Given this list of marker genes Inppl1, Pip4p1, Rab14, Mtmr12, Arf3, Bmx, Plekha8, Tpte, Pi4ka, Inpp4a, Pik3c3, Pik3r1, Inpp5k, Gde1, Pikfyve, Pik3cd, Mtmr4, Tnfaip8l1, Pik3c2g, Pik3r5, Plekha3, Inpp4b, Plekha6, Pi4k2b, Ptpn13, Pi4k2a, Mtm1, Inpp5d, Pik3r3, Inpp5j, Pik3cg, Fig4, Arf1, Inpp5f, Rab5a, Pik3c2b, Sacm1l, Tnfaip8 (tumor necrosis factor, alpha-induced protein 8), Pik3r2 (NCBI Gene Id 18709), Mtmr2 (NCBI Gene Id 77116), Mtmr1, Mtmr6, Pik3ca, Pitpnb, Sbf1, Pip4k2c, Vac14, Tnfaip8l2 (NCBI Gene Id 99931), Pten, Mtmr7, Pik3r6 (phosphoinositide-3-kinase regulatory subunit 5), Synj2, Pnpla6, Inpp5e, Mtmr14, Pik3r4, Plekha2, Rab4a, Synj1, Pip4k2b, Ocrl, Pip5k1c, Plekha5, Pik3c2a, Enpp6, Mtmr3, Rufy1, Pi4kb, Pip5k1a, Pik3cb, Plekha1, Plekha4, Pip4k2a, Pip5k1b, Tnfaip8l3, Mtmr9, here is a description of the gene set: PI Metabolism Mouse Gene Set: REACTOME_PI_METABOLISM species: Mus musculus